The following is a description of a gene set: Mouse Gene Set: GOBP_REGULATION_OF_SYNAPTIC_VESICLE_CLUSTERING studied in species Mus musculus Any process that modulates the frequency, rate or extent of synaptic vesicle clustering., and this is the list of marker genes: Bcl2l1, Cdh2, Snap91, Nlgn1, Pten, Nlgn3, Picalm, Nlgn2, Magi2, Pcdh17 (protocadherin 17)